The following is a description of a gene set: studied in species Mus musculus Mouse Gene Set: GOBP_TRIGEMINAL_GANGLION_DEVELOPMENT The process whose specific outcome is the progression of a trigeminal ganglion over time, from its formation to the mature structure., and this is the list of marker genes: Six4, Nrp1, Sema3a, Nrp2, Six1